The following is a description of a gene set: Human Gene Set: HP_ABNORMAL_NERVOUS_SYSTEM_ELECTROPHYSIOLOGY studied in species Homo sapiens An abnormality of the function of the electrical signals with which nerve cells communicate with each other or with muscles as measured by electrophysiological investigations. Abnormal nervous system electrophysiology, and this is the list of marker genes: PTRH2, NEFL, MOGS, STUB1, KCNT1, PDHA1, NOTCH1, LITAF, GOLGA2, EEF1A2, PRKCZ, MT-CYB, PPP3CA, SLC5A7 (solute carrier family 5 member 7), PDE2A, GRIN2D, GRIA4, SLC13A5, NDUFA9, TBC1D2B, RETREG1, NF1, PRPH2, CPLX1, PACS2 (NCBI Gene Id 23241), CTDP1, MYT1L, DALRD3, YME1L1, SMS, CELF2, HSD17B4, MTRFR, NACC1, PIGS, SCN2A (sodium voltage-gated channel alpha subunit 2), SNX10, OSTM1, NECTIN1, GABRB1, ERCC1, P4HTM, ROGDI, PEX14, TPI1 (NCBI Gene Id 7167), ANKRD11 (NCBI Gene Id 92821), OCRL, VCP, KCNQ2, CHCHD10, STRADA, PRUNE1, IER3IP1, PLCB1, GRIA1, ASL, DDC, ALG13, ATP7B, PCDH19, CACNB4, TIMM50, CNPY3, NUP133, HK1, TUBGCP2, SLC25A22, MARCHF6, FLVCR1, XPC, CYFIP2, SLC1A3, IREB2, YWHAG, ELOVL4, POMGNT1, PRODH, TBC1D24, ST3GAL5, BRAF, POLG, ABCA5, PEX11B, NEUROD2, TBL1XR1, TBC1D20, ZNF526, RAI1, ATP6V0A1, TGFB1, DPM2, STXBP1, GABRG2, FGD4, SOX10, KCNMA1, CHRNA2, PRX, ERCC5, ITGB6, ARHGEF10, CTBP1, POGZ, CLN5, CDKL5, DPYD, ZNF148, GARS1, MEGF10, CPT1C, DHDDS, SBF2, AASS, SNAP25, WNK1 (NCBI Gene Id 9872), MED23, MT-ND1, CHD2, NHLRC1, HYCC1, ERCC2, DENND5A, SLC25A10, ABCD1, FARS2, TYR, MT-TW, SNRPN, SCN8A, DOCK7, CAPRIN1, CBS, AIFM1, DPAGT1, AGRN, ARHGEF9, SPTAN1, SUOX (sulfite oxidase), AP1S2, MAP2K2 (NCBI Gene Id 85511), SAMD12, KANSL1, ABAT, ANKRD17, EPG5, CHMP2B, CABP4, IDUA, SNF8, MTHFR, SPTLC2, ALS2 (NCBI Gene Id 65058), NOTCH2NLC, PEX12 (peroxisomal biogenesis factor 12), FGFRL1, SLC6A1, SV2A, PCDH12, PIGV, SYNJ1, DRD3, GJC2, MECP2, PMP2, FOXG1, ITPR3, ADK, DEGS1, ALG1, ATP10A, FGF12, ARHGEF2, CCDC47, SMC1A, HSPB1, FBN1, MED13L, CNTNAP1, DAG1, ADGRG1, DCX, ATXN1, CLCN7, ARFGEF2, HPDL, ERCC6, POMT1, GNB1, DNM1, SIGMAR1, TNFSF11, GNB2, NDRG1, GUF1 (NCBI Gene Id 60558), PRKAG2, TRAPPC11, DHH, NDP, ATP1A2, NTRK1, ASNS, ITPR1, DOCK6, SPTLC1, MADD, ATP7A, RNF170, MFF, ZEB2, MT-TS2, EOGT, ERCC8, RPL10, DNM1L, DEAF1, CYP27A1, NUP188, SKI, DPM1, DDB2, APOL4, HECW2, CHRNA4, SCAPER, PEX19, ARFGEF1 (NCBI Gene Id 25860), NTNG1, PEX5, SPEN, MGAT2, NALCN, MT-TH, HRAS, TRAF3, SLC9A6, PIGT, SATB1, SNIP1, OTUD7A, NDUFAF8, PNKP, COL13A1, STARD7, PMP22, UBTF, TRIM2, GCSH, GDAP1, IQSEC2, ATP11A, PEX6, GABRA5, PSAT1, GRM7, NDUFS4, NMNAT1, RAB7A, GABRB3, MT-ND6, VPS13A, SUCLA2, GLYCTK, WWOX (WW domain containing oxidoreductase), TREM2, MED17, KPNA3, SLC12A6, FOXP1, KCTD7, NEXMIF, AIMP2, HCFC1, NFASC, PIDD1, RRM2B, GABRA1, PGAP2, NSD2 (nuclear receptor binding SET domain protein 2), TRPM3, NSRP1, WDR4, CLN8, RERE, LMNB1, ACTL6B, FLCN, SLC25A1, UBE3A, ATP6V1B2, KCNQ3, CLTRN, CNTN2, FBLN5, SLC18A3, KCNJ18, FIG4, XPA (XPA, DNA damage recognition and repair factor), YEATS2, UCHL1, NLGN3, RUSC2, ATL1, PI4K2A, TBCK, MT-CO2, CCDC88A, SLC33A1, NTNG2, TFG, ST3GAL3, SCARB2, MAPT, CUX2 (NCBI Gene Id 23316), CASK, CEP126, HSPG2, SRPX2, GABBR2, SCN1B, TIMM8A, MTMR2, TTPA, GNB5, CILK1, CEP85L, LONP1, RTN4R, TCIRG1, ANTXR1, DLL4, LUZP1, PIGO, AHSG, HID1, AFG3L2, TPRKB, DHPS, HIKESHI, SPG7, TP53RK, SNAP29, FGF13, MT-ND5, ABCA4, CLN6, MAP1B, SLC2A1, AIMP1, ATAD1, SLC25A15, SUMF1, PIGQ, MORC2, LAMC3, LETM1, MT-CO3, FBXO28, STX1B, AHDC1, DHX16, LRSAM1, JRK, OCA2, GLUD1, LIG3, COX16, POMT2, NPRL3, OPA1, SYNGAP1, MPV17, CARS2, SZT2 (NCBI Gene Id 79597), NEU1 (neuraminidase 1), TRPV4, SETX, CUL4B, NLRP3, PLPBP, HMGCL, DMXL2, MAF, CRPPA, MT-ND4, TET3, C1QBP, PROM1, DNM2, CLCN4, SLC32A1, SPG21, MAPK10, TMEM106B, RELN, ESAM (NCBI Gene Id 90952), SIK1, CACNA1S, HIC1, GAD1, PHACTR1, SCN9A, PRNP, TRAPPC12, EPM2A, CAMSAP1 (NCBI Gene Id 55490), MFN2 (NCBI Gene Id 9927), AARS1, CLCN2, ADRA2B, GLS, FLII, ALG11, EBP, APC2, ALG14, CACNA1A, PNPO, GRN, GFM2, AP3B2, PSAP, PTS, TRAK1, MYO9A, NRAS, GABRB2, ATN1, UBA5, AARS2, SACS, NLGN4X, UFC1, PEX3, PIGL, YWHAE, PLP1, CTNND2, DAOA, BCKDK, CDK5, CREBBP, ADGRV1, SLC38A3, ABCB7, VARS1, APOL2, FRRS1L, GRIA3, GRIN2A, PARS2 (prolyl-tRNA synthetase 2, mitochondrial), MPDU1, NUP107, RFC1, BCS1L, EXOC8, PDK3 (pyruvate dehydrogenase kinase 3), PRRT2, UNC80, PLCH1, CLCN6, MAP2K1, RNF13, GPAA1, CASZ1, CACNA1B, KCNJ11, SHQ1, LSS, CPA6, PDPN, KCNB1, GON7, PHGDH, HSPB8, CNTNAP2, CPLANE1, RDH11, MPZ (NCBI Gene Id 4359), PURA, FDXR, KCNA1, ATP1A3, REEP1, KDM6A, CADM3, LTBP3, FZR1, D2HGDH, ERCC4, HNRNPU (NCBI Gene Id 3192), CACNA1G, AKT3, COL6A1, MTHFS, AP2M1, PIGY, PIGP, EFHC1, SCP2, TFE3, COX6B1, OSGEP, RAB3GAP1, SH3TC2, NTRK2, ATXN10, GABRA2, PRDX3, LMNA, CERS1, NGLY1 (N-glycanase 1), TYMP, NEDD4L, EIF2S3, CLTCL1, GOSR2, WDR62, EMC1, NARS2, LYST (NCBI Gene Id 1130), TICAM1, B3GALNT2, SQSTM1, LGI1, RTTN, KPTN, LAMA2, ARG1, COMT, KMT2D, CACNA2D1, NECAP1, EDNRB, FKRP, SORD, MATR3, HIBCH, GNAO1, KCNH1, ATL3, TRIM8, MDH1, CAMK2A, CACNA1E, RAB18, GRIN2B, PIK3CA, KARS1, KRAS, IGHMBP2, UBAP1, PRICKLE1, SYN2, COX4I1 (cytochrome c oxidase subunit 4I1), PRPS1, PLA2G6, TBK1, MT-ND2, UGDH, KCNC1, SLC35A2, DNAJC3, UBA1, MT-TL1, DEPDC5, GABRA3, ARHGAP31, SEMA6B, NAXD (NCBI Gene Id 95526), MECR, MMP23B, NBEA, LIPT2, UQCRC1, MYH14, TLR3, EGR2, MT-TF, SLC1A4, KCNAB2, IARS2, PIGG, TRIT1, TUBB2A, SETBP1, SYT1, LARS2, HTR2A, ZNHIT3, PEX26, SPTBN4, PGAP3, YRDC, SLC44A1, SETD1B, NSF, FXN, PNPT1, PPT1, SBF1, OTOF, CRH, COQ4 (NCBI Gene Id 51117), COG3, VAMP1, ERCC3, CDK19, JPH1, DNAJC30, ALG3, FKTN (NCBI Gene Id 2218), SLC12A5, BSCL2, CNKSR2, SLC1A2, ACOX1, PI4KA, RIPOR2, NPRL2, DCAF8, PAFAH1B1 (NCBI Gene Id 5048), PIGW, TDP1, PEX10 (NCBI Gene Id 5192), UPB1, ASPA, SLC25A46, KCNT2, SAMD9L, CHAT, MFSD8, ARV1, ALDH4A1, CLTC, DIAPH3, ERMARD, MYH3, GALC, GRIN1, LAGE3, AAAS, ARSA, ABHD12, ALDH7A1, FBXO38, MT-CO1, TPP1, CHRNB2, KIF1A, PEX1, CNGB3, LRPPRC, GJB1, PEX16, RBPJ, PIGA, PSEN1, PEX2, BRAT1, ADARB1 (adenosine deaminase RNA specific B1), CTNNA2, CACNA1H, KCNA2, LARGE1, NOTCH3, FLNC, CCT5, MTOR, EMILIN1, SLC39A8, NUS1, NDUFS2, RMRP, ARX, SCN3A, PLEKHG5, TYROBP, DOLK, PPFIBP1, MT-ATP6, RTN2, ALDH5A1, WASHC5, MYD88, MCOLN1, CWC27, ATP6V1A, CSTB, WDR73, VAMP2, KIF1B, MT-ND4L, ALG2, WDR45, UNC93B1, KCNC2 (potassium voltage-gated channel subfamily C member 2), VARS2, AMT, HCN1, UBE4B, PTPN23, AFG2A, RAB3GAP2, YARS1, SLC6A19, GMPPB, PCK1, PLAA, PRDM16, PHF6 (PHD finger protein 6), GABRD, EP300, SPG11, DNAJB6, AP3D1, MT-TQ, CUL3, SCN1A, ABCC8, CHI3L1, SYT2, MED25, SPTBN1, PEX13